The following is a description of a gene set: Mouse Gene Set: GOBP_DERMATAN_SULFATE_PROTEOGLYCAN_BIOSYNTHETIC_PROCESS The chemical reactions and pathways resulting in the formation of dermatan sulfate proteoglycans, which consist of a core protein linked to a dermatan sulfate glycosaminoglycan. The dermatan sulfate chain is composed of the repeating disaccharide unit beta-(1,4)-D-hexuronic acid-beta-(1,3)-N-acetyl-D-galactosamine. Tthe former can be a mixture of sulfated and nonsulfated D-glucuronic and L-iduronic acids, and the latter can be O-sulfated. Dermatan sulfate chains are covalently linked to serine/threonine residues (O-linked) of the core protein via a tetrasaccharide linker sequence (xylose-galactose-galactose-glucuronate). studied in species Mus musculus, and this is the list of marker genes: B3gat3, Chst14, Chst12, Csgalnact2, B3galt6 (NCBI Gene Id 117592), Dse, Ust